The following is a description of a gene set: Human Gene Set: GOCC_MRE11_COMPLEX species: Homo sapiens Trimeric protein complex that possesses endonuclease activity; involved in meiotic recombination, DNA repair and checkpoint signaling. In Saccharomyces cerevisiae, the complex comprises Mre11p, Rad50p, and Xrs2p; complexes identified in other species generally contain proteins orthologous to the Saccharomyces cerevisiae proteins., and this is the list of marker genes: SP100, MRNIP, RAD50, MRE11, NBN